Given this list of marker genes SLC9A3, SLC6A14, DCTN4, STX1A, TGFB1, NCF1, CYBA, GCLC, SLC26A9 (solute carrier family 26 member 9), SLC11A1, CEACAM6, NCF2, EDNRA, CFTR, CEACAM3, MIF, GSTM3, SERPINA1, HMOX1, STAT1, CYBB, HFE, CLCA4, KCNN4, here is a description of the gene set: Human Gene Set: HP_RECURRENT_ASPERGILLUS_INFECTIONS An increased susceptibility to Aspergillus infections, as manifested by a history of recurrent episodes of Aspergillus infections. Recurrent Aspergillus infections studied in species Homo sapiens